Given this list of marker genes KCNK2, KCNQ5, CPLX1, CALB1, CALM3, GIT1, CALM2, KCNA2, KCNC1, TPRG1L, PRKCG, PRKCB, CPLX2, ACTB, CALM1, ACTG1, TSPOAP1, ADORA1 (NCBI Gene Id 134), NOS1 (nitric oxide synthase 1), UNC13C, here is a description of the gene set: species: Homo sapiens The terminal specialization of a calyciferous axon which forms large synapses in the mammalian auditory central nervous system. Human Gene Set: GOCC_CALYX_OF_HELD